Given this list of marker genes AMPD3, ADA, HPRT1, ADK, DCK, NAPRT, ADSL, DGUOK, ADSS1 (adenylosuccinate synthase 1), AMPD1, APRT, AMPD2 (NCBI Gene Id 271), here is a description of the gene set: Any process which produces a purine nucleotide from derivatives of it, without de novo synthesis. Human Gene Set: GOBP_PURINE_NUCLEOTIDE_SALVAGE species: Homo sapiens